Given this list of marker genes BMPR1B, GNAS, PIK3CD, MAP3K7, KNSTRN, FLNA, SALL4, PTCH1, here is a description of the gene set: Short distal phalanx of the thumb Human Gene Set: HP_SHORT_DISTAL_PHALANX_OF_THE_THUMB studied in species Homo sapiens Hypoplastic (short) distal phalanx of the thumb.